Given this list of marker genes Trim31, F12, Pin1, Apoe, Icam1, Usp7, Itgb1, Vcp, Tnfrsf14, Susd4, Dcst1, Rela, Pdcd10, Plxna3, Gcg, Trafd1, Bcl2l2, Parpbp, Usp14, Kmt5a, Dnm1, Xdh, Dusp16, Ffar4, Ptpn6, Lyar, Tap2, Adam17, Gbp7, Irak2, Zbtb7b, Nt5c2, Ceacam1, Cd274, Adamts18, Oprm1, Shank2, Ezh2, Appl1, Stk3, Bmp4, Oas1a, Lbh, Dkkl1, Vhl, Esr2, Hspa5 (NCBI Gene Id 99198), Vsir, Cav3, Efna1, Gsk3a, Slc35c1, Gnai3, Gli1, Dyrk2, Ints9 (integrator complex subunit 9), Palm3, Neurl1a, Tgfbr3, Nherf4, Slc6a3, Mapk3, Smim30, Rffl, Spink1, Mllt3, Map2k1, Sar1a, Cdc42se1, Cd46 (CD46 antigen, complement regulatory protein), Slc25a4, Sar1b, Xrcc1, Dact2, Znrf3, Naip5, Tns2, Ivns1abp, Aif1, Socs5, Dok1, Tax1bp1, Trim21 (NCBI Gene Id 20821), Nr1h2, Fam3a, Map3k7, Nlrp4e, Bmper, Rnf149, Gnai2 (G protein subunit alpha i2), Dab1, Psen1, Gpx2, Xbp1 (X-box binding protein 1), Cit, Stmn3, Krt1, Lrp2, Pik3r2, Sfrp2 (secreted frizzled-related protein 2), Kremen1, Myoz1 (myozenin 1), Oas1b, Wwtr1, Cd160 (NCBI Gene Id 99838), Gprasp1, Nfe2l2, Svip, Ncoa5, Rgs19, Inppl1, Arhgap42, Arhgap29, Acod1, Tlr9, Bok, Mir143, Stk38, Shh, Cby1, Sufu, Ubac2, Pdcd4, Styxl2, Prkar2a, Ifi213, Trp53, Park7, Mdfi, Cadm4, Tpsab1, Cyp19a1, Hmox1, Gstp-ps, Mefv, Epha7, Plk1, Serping1, Mvp, Pim1, Sorl1, Heyl, Mvk, Gpr155, Lpar1, Smad7, Kdm1a, Grb14, Veph1, Nlrc5, Tnk1, Grb2, Rgs5, Ubxn1, Robo2, Gp5, Rnf43, Pea15b-ps, Bak1, Itga6, Trp63, Mul1, Inpp5f, Cdk5rap3, Tbc1d7 (NCBI Gene Id 67046), 2210016L21Rik, Chp1, Cnksr3, Pglyrp4, Ptpru, C1qtnf1 (NCBI Gene Id 72004), Sarm1, Syvn1, Prkcd, Amer2, Bcl3, Pdia6, Tob1, Cttn, Ddrgk1, Btn2a2, Bag5, Phlda3, Arrb1, Pp2d1, Ctnnb1, Magi2, Adipor1, Tnfrsf23, Mre11a, Drd2, Klkb1, Tle2, Bpifb1, Ccl12, Pafah1b1, Fcrlb, Syt11, Wtip, Hamp, Pias4, Mpv17l, Dll4, Yap1, Sh3rf1, Trim60, Brd4, Tbx21, Csf2, Rbbp7, Fgl2, Stat2 (signal transducer and activator of transcription 2), Isg15, Shisa3, Mtm1, Eno1b, Aplp1, Nck2, Il17rd (interleukin 17 receptor D), Runx2, Plaur, Fcmr, Mapk7, Trim45, Ywhag, Reg3a, Faim2, Heg1, Snx13, Ripor2, Ifi203, Wfdc1, Gper1, Ly6g6e, Myadm, Pdgfb, Rtn4rl1, Peli1, Clec2d (C-type lectin domain family 2, member d), Mgrn1, Necab2, Rasl11b, Nxn, Hfe, Cd96, Mcc, Depdc5, Cptp, Foxh1, Plin5 (NCBI Gene Id 66968), Nodal (nodal growth differentiation factor), Kdm6a, Cd22, Noc2l, Lfng, Nkx3-1, Rgs4, Cryba1, Erbin, Il2, Rasip1, Drd3, Ccr2, Rasal1 (NCBI Gene Id 19415), Aph1c, Sall1, Cblc (NCBI Gene Id 80794), Wnt3, Leprot, Tnfaip8l1, Pla2g10 (phospholipase A2, group X), Pip4k2c, Ncor1, Cib1, G2e3, H2-T23, Mup11, Wnt16, BC037156, Socs2, Pycard, Kctd6, Vtn, Raf1, Lmna, Trim59, Sirpa, Adamtsl2, Creb3l1, Ecm1, Prkar1a, Tnip2, Cd69, Foxj1, Zdhhc12, Sfrp5, Cd9, Git1, Ube2n, C1qbp, Chrna10, Fam89b, Eif3a (NCBI Gene Id 320318), Eya4, Sec14l1, Prkaa1, Nlrc3, Tnfrsf1a, Tsc2, Tbx20, Phb1, Hdac1, Grb7, Stat6 (signal transducer and activator of transcription 6), Chrdl2, Hif1an, Smad5, Cflar, Reg3b, Mcl1, Npy5r, Cask, Lats1, Hspa8, Dusp7, Aurka, Nrg1, Nanog, Egf, Limd1, Megf8, Pde8b, Robo1, Sost, Zfp451, Ptprt (protein tyrosine phosphatase receptor type T), Coro1b, Suz12, Il1rn, Ggnbp2, Tmem53, Dlc1, Ikbkb, Spart (spartin), Pip4k2a, Tbc1d10c, Ppif, Fstl3, Fzd9, Ddit3, Parp14, Ndrg4, Cd300lf, Mup4, Itgav, Cthrc1, Mill1, Btrc, Cblb, Zbtb7a, Phip, Psen2, Mndal, Masp1 (NCBI Gene Id 17174), Nlrp4f, Irak3, Tspan15, Wnt5a, Stk11, Agap2, Gstp3, Mkks, Erfe, Dsg2, Chmp6, Ncoa7, Tlr6, Akt3, Ppara, Ofd1, Ube3a, Ptprc, Eif2ak3, Ttll12, Timp2, Rgs10, Ppp2r3a, Vdac2 (voltage-dependent anion channel 2), Naip2, Arhgap44, Rrn3, Vps11, Tcf7l2, Pycr1, Bank1, Tcf21, Igbp1, Spx, Mstn (myostatin), Higd1a, Fst, Rgs8, Shisa6, Dand5, Chrdl1, Mrap2, Jak3, Nmi, Myoc, Tnfrsf1b, Banf1, Prkcq, Sh2d1b1, Nkx2-5, Hspa1b, Emilin1, Ddias, Maz, Akt2, Tmem127, Tnfsf4, Igf1, Sfn, Scai, Ldlr, Trabd2b, Apod, Sigirr, Pparg, Spred2, Asb15 (NCBI Gene Id 78910), Il4, Rgma, Il1r2, Tjp2, Recql5, Pcbp2, Rbbp4, Pla2g5, Nenf, G3bp1, Cpb2, Arg2, Ufl1, Leprotl1, Creb3 (NCBI Gene Id 97162), Usp18, Gpc1, Lingo1, Nrros, Uaca, Adipoq, Tnf, Ing1, Nherf2, Ubqln4, Pyy, Ajap1, Litaf, Polq, Bmal1, Slit1, Ywhaz, Adcyap1r1 (adenylate cyclase activating polypeptide 1 receptor 1), Stradb, Cers2, Crk, Nf2, Dlk2, Reg3g, Cldn18, Amfr, Bmp7, Tradd, Cidea, Nedd4, Dact1, Sulf1, Klhl31, Fer, Rb1, Dkk4, Naip1, Pbld2, Tlr4, Usp47, Dnajb9, Nectin2, Sox2, Klre1, C5ar2, Irs1, Ctnna2 (NCBI Gene Id 12548), Sike1, Psma1, Cx3cr1, Nkiras1, Aph1b, Ier3, Epha4, Cst7, Apln, Pglyrp2, Muc16, Clasp2, Sac3d1, Psg23, Lect2, Eny2, Sirt3, Cd59b, Rita1, Rgs12 (NCBI Gene Id 77052), Il33, Grk4, Sstr4, Rgs16 (regulator of G-protein signaling 16), Smchd1, Tnfaip1, Anxa5, Rhoa, Mfhas1, Foxo1, Grina, Siglece, Ybx3, D130043K22Rik, Cav1, Hdac2, Traip, Hspb1, Usp49, Nbl1, Fhl2, Pttg1ip, Ercc4, Kng2, Tgfbr1, Becn2 (NCBI Gene Id 226720), Madd, Rasa4, Apoh (apolipoprotein H), Akt1s1, Ptprj, Serpinb9f, Ercc1, Pim3, Dkk3, Agt, Il1b, Npc1, Cul3, Cd276, Sox9, Pik3cb, Cr2, Grk5, Rgs18, Rmi2, Aim2, Gpx1, Synj2bp, Ube2w, Tnip3, Grem2, Lzts2 (NCBI Gene Id 226154), Trim38, Nploc4, Aida (NCBI Gene Id 72487), Prkn, Nphp4, Bmp5, Eya2, Ppm1b, Bcl6, Chrna7, Smurf1, Prkacb, Aoah, Cactin, Tert, Tmc8, Mup1, Fzd6, Btnl2, Gpd1l, Tfpi, Pde3a, Mtnr1b, Riox1, Mad2l1bp, Gpr108, Cbl, Fyn, Twist1, Rgs7bp (NCBI Gene Id 77218), Cnot9, Bcl2l12, Rtn4, Ghrl, Wnt1, Pdx1 (pancreatic and duodenal homeobox 1), Sesn2, Lrrk2, Rgs22, Fpr-rs7, Trim72, Zfp366, Actn3, Apela, Cd200l1, Zp3r, Hdac7, Nrarp, Akt1, Cd44 (CD44 antigen), Herpud1, Metrnl, Grin3a, Nr5a2, Inpp5d, Phf14, Ddit4l, Ltf, Snx1, Dusp1, Tnfrsf4, Parp3, Faim, Gps2, Kif7, Pea15a, Lrp1, Snx25, Tmx1, Otub1, Cxcl13, Csk, Rtn4r (NCBI Gene Id 65079), Slit3, Gdnf, C1qtnf12, Sbno1, Nlrx1, Cd59a, Lgals9, Ets1, Ifi206 (NCBI Gene Id 240921), Lgmn, Wnt11, Nlk, Nlrp4a, Nr1h5, Lefty1, Gdpd5, Dtx4, Rnf213, Nr1h3, Itprip, Cnot2, Arg1, Zfp36, Eno1, Dlx1, Stap1, Peli3, Klf7, Ovol2, Pten, Il22ra2, Atm, Mettl3, Laptm5, Ptgs2, Zfp385a, Abr, Cyld, Lilrb4a, Stub1, Dpp4, Il19, Dcn, Fpr2, Tsg101, Rgs17, Kif26a, Pf4, Tet1, Ror2, Grin1, Ripor1, Ifi209, Traf3ip1, Cnot7, Gdf3, Cntnap2 (NCBI Gene Id 66797), Nkd2, Ppp1r13l, Ikbkg, F2, Itpr1, Ccr1, Col2a1, Mark3, Fxn, Fbp1, Cacnb3, Ins2, Cdh3, Sox30, Cd55, Gp1ba, Ifi207, Rif1, Prdx2, Alg13, Strn4 (striatin, calmodulin binding protein 4), Rnf31, Ackr3, Trp53bp1, Egfr, Fuz, Lpcat3, Wnt4, Acp5, Muc4, Lemd3, Ifnb1, Fpr-rs3, Morn3, Ythdf2, Klrb1b, Kctd11, Wnt7b, Cd109, Clasp1, Angpt2, Lgr4, Ace2, Atxn1, Men1, Ptpn1, Spry1, Ptprr, Scly, Cish, Stat1, Ruvbl2, Chrna9, Grk6, Sema5a, Drd4, Serpine2, Nfkb1, Phldb2, Axin2, Pdpk1, Tnfsf18, Tkfc (triokinase, FMN cyclase), Triap1, Ryr1, Dab2ip, Sco1, Slc25a5, Ndufs3, Mup3, Ndufc2, Xiap (NCBI Gene Id 74774), Tff2, Clu, Samhd1, Gas6, Chuk, Dnm2, Socs7, Gfral, Bdkrb2, Oas1c, Cmya5, Cyren, Pld2, Onecut1, Nf1, Mavs, Tle5, Rapgef1, Rc3h1, Lrp4, Prdm15, Nod2, Fbln1, Tmem161a, Snx6, Grm5, Plek, Vps18, Chek2, Bace1, Plcl2, Skil, Neurod1, Nol3, Fabp7, Hnf4a (hepatic nuclear factor 4, alpha), Fbh1, Birc7, Mir675, Ptpmt1, Csnk1a1, Sh3bp1, Rack1, Arhgap25, Fgg, Ifi214 (interferon activated gene 214), Cdkn2d, Chac1, Mecom, Dusp29, Dusp19, Daxx, Rcan1, Aspn, Selenos, Ccnc, Nepn, Htra1, F2rl1, Gata1, Snca, Pglyrp3 (NCBI Gene Id 242100), Lrfn5, Pip4k2b, Eya1, Pglyrp1, Armc10, Sgk3, Rtkn2, Xrcc4, Ada (NCBI Gene Id 11486), Cadm1, Itga1, Cx3cl1, Ndrg2, Dab2 (disabled 2, mitogen-responsive phosphoprotein), Crebrf, Dact3, Oas3, Bbs2, Ufd1, Nog, Sqstm1, Ppm1a, Ulk3, Tax1bp3, Shisa2, Keap1, Castor1, Havcr2, Notum, Pid1, Ccdc125, Bfar, Mrap, Usp15, Trap1, Ddit4, Gata4, Cav2, Sostdc1, Szt2, Wdr91, Cyrib, Itga3, Dvl1, Hjv, Hacd3, Dlx2, Ptch2 (NCBI Gene Id 19207), Hipk3, Prdm16, Prkar1b, Rhoh, Mapkapk5, Sin3a, Plk3, Erbb3, Dll3, Ppp2ca, Bid, Cer1, Neo1, Nppa, C9orf72, Lemd2, Dyrk1a, Fancb, Inpp5a (inositol polyphosphate-5-phosphatase A), Ahr, Mmp14, Ankrd26, Blvrb, Sesn1, Ddah1, Cd200l2, Tle1, Cd74, Usp38, Insig1, Aqp11, Igtp, Ppp3ca, Ern1, Bicc1, Parl, Brms1l, Entrep1, Alox15, Gprc5a, Drd1, Rc3h2, Aars2, Rps6ka6, Tafa5, Sall3, Pros1, Cnot3, Dusp13b, Klf4, Rab7, Phpt1, Bicd1, Sgf29, Muc19, Ptgs2os, Mapk14, Snai1, Il10ra, Gpr18, Nphp3, Aurkb, Trim67, Spaar, Dkk1, Ptprs, Hipk2, Pde1c, Dsg3, Rfng, Shld1, Ilrun, Spry4, Eif2a, Map4k4 (mitogen-activated protein kinase kinase kinase kinase 4), Hdac6, Lyplal1, Aplnr, Il4ra, Elf1, Arhgap17, Bax, Prkg1, Camk2b, Tgif1, Plau, Sap30l, Adcyap1, Rps6ka1, Ascl2, E130311K13Rik, Pbld1, Socs4, Gclm, Nherf1, Fbxw11, Adtrp, Pde11a (phosphodiesterase 11A), Nkiras2, Adora2a, Gpr161, Prkar2b, Eppk1, Sod2, Nlrp3, Dgkg, Smpd3, Nr1h4, Hic1, Gclc, Rrm2b, Bend6, Ctdspl2, Adora1, Oas1f, Nrxn1, Spn, Ptpre, Rgs7 (regulator of G protein signaling 7), Atg5, Usp10, Mlip, Pde4c, Zgpat, Parp1, Pbp2, Adra1a, D1Pas1, Irgm1, Mfn2, Tfap2a, Frzb, Txndc12, Commd1, Pdgfra, Tnip1, Ptgir, Rps3, Ptgis, Scyl2 (NCBI Gene Id 52687), Sgta, Rnf169, Cd3e, Itch, Snx5 (NCBI Gene Id 99195), Gli3, Ajuba, Endog, Adra2a, Wwc1, Wnk2, Bmf, Ppia, Nprl3, Snip1, Dyrk3, Klk14, Sirt1, Fga, Ccdc22, Arhgap24, Csnk2a1, Clec4g, Serpinb9b, Ppef2, Them4, Syngap1, Dok2, Nlrp4c, Pvrig, Mdm2, Sirt2, Ltbp1, Dlk1, Ggt7 (NCBI Gene Id 207182), Bmt2, Il12b, Fxr1, Igf2, Rgs9bp, Chst11, Hells, Dag1, Dgkd, Fgf9, Sirt7 (sirtuin 7), Pik3ap1, Cdk3, Rassf2, Hrg, Ngfr, Ski (NCBI Gene Id 99956), Dusp8, Mdk, Pebp1, Rgs13, Arnt, Il6st, Vwc2l, Rasal3, Smpd1, Egr1, Rnf113a1, Dlg1, Atad5, Ncor2, Arrb2, Il1rl1, Prkaca, Bdnf, Elf4, Ptpn22 (protein tyrosine phosphatase, non-receptor type 22 (lymphoid)), Il22b, Mesp1, Irf4, Pde3b, Esr1, Per1, Palm, Klrd1, Vps25, Casp8, Rps6kb2, Trim32, Ppt1, Ctla2a, Klhl15, Tmbim6, Ubqln1, Ube2d1, Ptprf, Notch1, Sh3bp4, Cd2ap, Lrrc14, Ephb2, Serpinb9, Smpdl3b, Rnf170, Lyn, Grk2, Axin1, Dmd (dystrophin, muscular dystrophy), Otud5, Apc, Lrrc32, Pfdn5, Apc2, Ogt, Tnfrsf11b, Suds3, Cpne1, Mkrn2, Minar1, Tnfaip6, Abhd17a, Smurf2, Mir423, Plat, Acp4, Stambp, Pcgf2, Smad4, Grb10, Gas1, Mctp1, Hgs, Proc, Twsg1, Abl2, Il36rn, Sesn3, Gba1, Sh3glb1, Optn, Sfrp1, Birc6, Map2k3, Lpxn, Apcdd1, Zfp536, Spry2, Pibf1, Tbx1, Arid4a, Jade1, Hsf1 (NCBI Gene Id 15499), Prkcb, Arid4b, Itpripl1, Ifi208, Ankrd6, Tbx18, Fcrl5, Rnf113a2, Gpc3, Senp3, Fem1a (fem 1 homolog a), Map3k20, Hc, Clec12a, Il20rb, Ghitm, Tsc1, Hmgcr, Deptor, Agtr2, Ucp2, Pak5, Rasa3, Wdr41, Kctd21, Ppp6c, Oas1g, Arrdc1, Rab7b, Mif, Diaph1, Dusp26, Dusp2, Usp20, Dnaja1, Ucma, Nfkbid, Fzd1, Fnip1, Met, Tnfaip3, Mir210, Anxa1, Mnt, Oas1e, Calr, Macroh2a1, Prex1, Mapkbp1, Rgs6, Gata3, Rabgef1, Dusp10, Fbn1, Il12a, Wfs1, Mapkap1, Nanos3, Sema6a, Mtor, Dusp6, Rgs2, Ptpro, Eif4e2, Tmed2, Otud7b, Asb3, Nme5, Fbxo7, Cul7, Spi1, Tle6, Znrf4, Pink1, Oprl1, Nlrp4b, Map2k5, Apoa1, Siah2, Ptger3 (prostaglandin E receptor 3 (subtype EP3)), Serpine1, Xylt1, Wwox, Prkca, Homer2, Stk4, Vps35, Myoz2, Siglecg, Uchl1, Ppard, Taok3, Cnot1, Rpgrip1l, Kctd10, Tsku, Tap1, Il10, Serpinb9h, Prickle1, Kptn, Egfl7, Trim30a, Sla2, Strip1, Grn, Mmrn1, Ercc6, Trim33, Rnf125, Arhgap22, Rnf167, Pak1ip1, Kank2, Phlpp1, Prkaa2 (protein kinase, AMP-activated, alpha 2 catalytic subunit), Sh3rf2, Ska1, Dkk2, Mdm4, Rbpms2, Pias2, Mtmr4, Fpr-rs6, Plekha1, Mir7578, Zmynd11, Ldlrad4, Pawr, Ubxn2a, Gdf15, Tpbgl, Tgfb3, Mup5 (major urinary protein 5), Rian, Trim15, Fgfrl1, Hmgb2, Rbx1, Rfx4, Oas1d, Gfer, Ins1, Gpr17, Loxl3, Ywhab, App, Stat3, Sox13, Trim39, Serpinb9c, Tpbg, Cldn3, Bcl2l10, Glg1, Tle7, Vsig4, Thbd, Clock (clock circadian regulator), Lmo3 (NCBI Gene Id 16910), C1qtnf3, Ndufaf2, Gipr, Arhgap35, Cgnl1, Spsb3, Il22ra1, Mosmo, Epm2a, Alox5, Prap1, Dll1, Cgas, Skor1, Socs6, Capn1, Mdga1, Foxp3, Lif, Ghsr, Smcr8, Ing2, Tyro3, Serpinb9e, Cry1, Tnfrsf22, Avp, Cdk11b, Dusp5, Hyou1, Barx1 (NCBI Gene Id 12022), Gpr37l1, Tspan6, Fignl1, Itgb1bp1 (NCBI Gene Id 16413), Dnaja3, Chrd, Egln1, Nfkbil1, Pde10a, Bmp2, Alpk2, Ucn, Tmem64, Slc2a10, Rora, Arhgap12, Bcl9l (NCBI Gene Id 80288), Atad3a, Socs3, S2bpcox16, Ccar2, Grk3, Adra1b, Trem2 (NCBI Gene Id 83433), Foxo3, Ift172, Hey1, Nono, Wnt5b, Kank1, Gstp2, Obscn, Igfbp5, Fermt1, Ppp2r1a, Ubr5, Gsc, Cdk20, Unc5b, Dbn1, Fgb, Insig2, Setd7, Cck, Cavin3, Foxf1, Atxn3, Ctnnbip1, Oga, Qars1, Pbk, Cdh1, Tmbim1, Il7, Isl1, Aunip, Nprl2, Cxcl17, Kat5, Il13, Cartpt, Adm, Nectin4, Bcr, Plg, Cxxc4, Ptger4, Ticam2, Ptprd, Dusp22, Adar, Gli2, Ddx39a, Prkdc, Aatf, Rgs14, Il17a, Mpig6b, Prnp, Rgs20, Slc39a8, Cd80, Smad6, Src, Fem1al, Lilrb4b, Cdc34b, Phb2, Lax1, Grid2, Herc2, Ranbp9, Dlg5, Marveld3, Nup62, Pkia, Fam76b, Treml1, Otud4, Brap, Ifi203-ps, Mmp3, Zfp35, Csnk1e, Slit2, Ddx3x, Thbs1, Nlrp6 (NCBI Gene Id 101613), Nckap1l, Prex2, Ctnna1, Spred1, Oas1h (2'-5' oligoadenylate synthetase 1H), Fkbp1b, Gsdma3, Olfm4, C4bp, Paqr3, Sod1, Foxm1, Anxa2, Dhrs3, Gpr31b, Tulp3, Tmprss6, Lgals3, Pdgfa, Hmga2, Zc3h12a, Wnt3a, Ywhae, Ash1l, Cyp2j6, Vrk3, Wfikkn1, Cxcl12, Dusp3, Appl2, Ubqln2, Serpinb9g, Invs, F11, Defb21, Itfg2, Frmd8, Dusp4, Shld3, Notch4, Kng1, Rnf34, Homer3, Lats2, Errfi1, Uri1, Rnf26, Nos3, Epn2, Tgfb2, Mmp12, Acaa2, Gsk3b, Nfatc4, Adamts12, Gigyf2, Ubash3b, Tle4, Cbfa2t2, Rnf26rt (ring finger protein 26, retrotransposed), Slc25a31, Lep, Tbc1d1, Vegfa, Atg12, Irf1, Nkx2-1, Prelid1, Ripk1, Hhex, Pin1rt1, Bcl2, Sh2b3, Sema3a, Chd8, Col3a1, Il27ra, Lpl, Pdcd6, Fcgr2b, Cth, Fstl4, Inpp5k, Psme3, Flcn, Slc27a4, Rbck1, Tarbp2, Trim11, Samsn1, Extl3, Sh2d1b2, Cyp26b1 (cytochrome P450, family 26, subfamily b, polypeptide 1), Mad1l1, Lrp6 (NCBI Gene Id 77387), Mup2, Emd, Rbx1-ps, Ryk, Npy2r, Ppp3cb, Jagn1, Foxp1, Crtc3, Fbxl2 (F-box and leucine-rich repeat protein 2), Dgkz, Otud3, Phactr4, Arhgap45, Smpdl3a, Rgs3, Rubcn, Hhip, St6gal1 (NCBI Gene Id 224053), Grem1, Vwc2, Fkbp1a, Il22, Bambi, Tnr, Gpr21, Vgll4, Gstp1, Ndufa13, Mrtfa (NCBI Gene Id 223701), Pmepa1, Dynlt1b, Inpp5e, Huwe1, Marchf7, Ythdf3, Hapstr1, Prmt1, Sdhaf2, Fbn2, Psmb4, Naip6, Sh2d1a, Rnf152, Ccdc3, Sinhcaf, Tnn, Fpr-rs4, Pik3ip1, Zfyve28, Castor2 (cytosolic arginine sensor for mTORC1 subunit 2), Zfp653, Atf4, Trim27, Cd200r1, Tafa3, Enpp1, Psca, Ptch1, Mmp28, Il7r, Prdm14, Atp2b4 (ATPase, Ca++ transporting, plasma membrane 4), Dhx58, Nr1d2, Bcl2l1 (BCL2-like 1), Crhbp, Wwc2, Tldc2, Oxr1, Ift80, Cd24a, Ar, Htt, Ccl5, H2-M3, Nr4a2, Nucb2, Traf2, Riok3, Pam16, Otulin, Slamf1, Nt5e, Birc2, Peg10, Ogg1, Igsf1, Prkcz, Tmem131l, Pde2a, Otop1, Crhr2, Ubr2, Fgf2, Dicer1, Rps6kb1, Aars1, Tns3, Ncl, Nr1d1, H2bc21, Mmp9, Wnk1, Wfikkn2, Brms1, Eya3, Sema3f, Cep63, Tmsb4x, Wif1, Rbms3 (RNA binding motif, single stranded interacting protein), Slc35f6, Ifi35, Stmn1, Rtel1, Hdac3, Nrp1, Atf6b, Gpatch3, Meak7, Herc4, Tmem88, Il4i1, Rnf126, Asxl1, Cyp7b1, Ahsg, Lmbr1l, Nudt16l1, Yju2, Trib1, C1ql4, Mapk8ip2, Socs1, Lonp1, Bmi1, Slc12a2, Cripto, Zfp592, Tmem170b, Rnf146, Fndc4, Rasa2, Asah2, Tcim, Cnmd, Arr3, Adgra2, Tgfb1 (NCBI Gene Id 21803), Lrig2, Tnfaip8l2, Mapk8ip1, Arrdc3, Cd200, Gata2, Lgals1, Hgf, Brca1, Nfkbia, Pkhd1, Ift122, Cdh2, Tbk1, Irgm2, Draxin, Hyal2, Scg2, Fktn, Epo, Crim1, Acvr1, Tank, Mir154, Pdcd1, Il2ra, Dusp9, Bbs4 (NCBI Gene Id 52291, Bardet-Biedl syndrome 4), Enpp3, Amer1, Meis3, Atxn7, Alox12, Helb, Opa1, Tbc1d24, Cdc34, Cdkn2a, Fbxw8, Gramd4, Ube2b, Nlgn3, Kctd13, Psmd10, Sulf2, Mob4, Sap130, Ctnnd1 (catenin delta 1), Tmem14a, Igf1r, Diaph2, Mmrn2, Sag, Npy (neuropeptide Y), Sharpin, Tmem88b, Adrb2, Clec12b, Sfrp4, Ccn3 (cellular communication network factor 3), Six3, Abl1, Ndfip1, Smarca4, Rgs11, Tpt1, Adgrg3, Ell3, Cdh5, Spred3, P2rx7, Htra3, Abca7, Npff, Pcbp4, Slc24a4, A2m, Cilp, Serpinb9d, Ppp1r10, Sap30 (NCBI Gene Id 60406), Atf3, Ptpn2, Slamf8, Cd300a, Serpinf2, Usp25, Smad3, Tspan8, Hif1a, Lztr1, Sox17, Thy1, Cry2, Pde4d, Myocd, Sox10, Ubr1, Onecut2, Rph3al, Cd55b, Rtca, Edn1, Rgs1, Glis2, Hlx, Rps19, Ska3, Nop53, Lox, Tle3, Nck1, Prr5l, Ccdc88c, Klrk1, Trim65, Ezr, Strn3 (striatin, calmodulin binding protein 3), Rgs9, Ubash3a (ubiquitin associated and SH3 domain containing, A), Ptgr1, Mir147, Fgf10, Il6 (interleukin 6), Azi2, Cr1l, Shld2, Rb1cc1, Mad2l2, Faiml, Cldn19, Nlrp12, Nr0b1, Lamp2, Strap, Fgfr3, Slmap, Hey2, Nkd1, Snai2, Eid2, Zdhhc18, Kics2, Muc1, Macir, Radx, Gmip, Rin3, Skor2, Rnf115, Padi2, Trex1, Vasn, Ppp2cb, here is a description of the gene set: Mouse Gene Set: GOBP_NEGATIVE_REGULATION_OF_RESPONSE_TO_STIMULUS species: Mus musculus Any process that stops, prevents, or reduces the frequency, rate or extent of a response to a stimulus. Response to stimulus is a change in state or activity of a cell or an organism (in terms of movement, secretion, enzyme production, gene expression, etc.) as a result of a stimulus.